The following is a description of a gene set: studied in species Homo sapiens Human Gene Set: GOMF_TAU_PROTEIN_KINASE_ACTIVITY Catalysis of the reaction: ATP + tau-protein = ADP + O-phospho-tau-protein on serine and threonine residues., and this is the list of marker genes: MARK2, BRSK2, MARK3, TTBK1, MARK1, BRSK1, GSK3B, MARK4, TTBK2, CSNK1D